Given this list of marker genes Mllt1, Pycard, Stk38, Ubash3b, Notch1, Limk1, Gfi1, Dbndd2, Hpn, Ajuba, Cav1, Ormdl3, Lrch1, Akt1, Hipk3, Serpina5, Rpl23, Cdkn2c, Gadd45g, Nup62, Ptpn1, Zfp36, Lyn, Crb2, Ppia, Ptprc, Rd3, Park7, Dab2ip, Serpinb8, Epm2a (epilepsy, progressive myoclonic epilepsy, type 2 gene alpha), Cep43, Rb1, Abl1, Prkch, Serpinb9e, Nprl2, Amot, Sirt1, Rasip1, Prkag2, Sort1, Nr2f2, Eng (NCBI Gene Id 99055), Spink2, Stfa2, Cstdc6, Tsc2, Ptpn22, Dgkh, Slc27a4, Ins2, Cstdc5, Cav3, Nf1, Prdx3, Atp5if1, Nfkb1, Ppp1r12a, Lrp6, Cblc, Sh3bp5 (NCBI Gene Id 24056), Dusp7, Vtn, Irs2, Csta2, Trib1, Serpinb6e, Rap1gds1, Dusp10, Ptpro, Chmp6, Mvp, Tfap4, Dnaja1, Ptprj, Serpinb9b, Errfi1, Casp3 (caspase 3), Macroh2a1, Thy1, Akt1s1, Gstp-ps, Cdk5rap3, Bag5, Rpl5, Rgs14, Coro1c, Gzma, Adgrv1, Cln3, Slc4a1, Nos1, Garem1, Palm, Gadd45a, Serpinb9g, Mtrr, Fabp4, Fbxo5, Sh3bp4, Cand1 (cullin associated and neddylation disassociated 1), Pkia, Apcs, Lats2, Spink1, Cst3, Angptl4, Serpinb9d, Cdkn1c, Plxnb3, Men1, Cstdc4, Apoc1, Rtraf, Gadd45b, Mkks, Tmem225, Timp2, Hspb1, Tmed2, Apoe, Slc8a3, Dnaja3 (DnaJ heat shock protein family (Hsp40) member A3), Rrp1b, Apba3, Ecm1, Serpinb6a, Wwtr1, Plec, Cyp27b1, Ppm1e (protein phosphatase 1E (PP2C domain containing)), Fetub, Mapk8ip1, Tmbim6, Pkig, Ins1, Terf1, Gba1, Zfyve28 (NCBI Gene Id 231125), Pkn1, Neil1, Stfa2l1, Spink5, Gprc5a, Ptx3 (pentraxin related gene), Taf7, Cast, Serpinb1b, Ptprb, Lats1, Slc8a1 (NCBI Gene Id 319418), Cstb, Cdk5rap1, Wnk1, Agt, Ptk6, Prkrip1, Cep85, Drd5, Midn, Prkar1a, Snca, Cstdc3, Ptpn2, Mt3, Chordc1, Pkib, Adarb1, Itgb1bp1 (NCBI Gene Id 16413), Gnaq, Gla, Adipoq, Sfrp1, Mad2l2, Serpinb9c, Gstp3, Rgs2, Bin1, Shb, Prdx5 (peroxiredoxin 5), Hexim2, Serpinb9, Arfgef1, Ggnbp2, Rps7, Ppm1f, Dusp22, Serpinb9f (NCBI Gene Id 80600), Psen1, Trib3, Acp4, Ubxn1, Arl2, Npm1 (NCBI Gene Id 18148), Ccar2, Camk2a, Il7, Chp1, Stfa1, Gapdhrt2, Serpinb6c, Dusp19, Fem1a, Stfa3, Inca1, Dtnbp1, Tsg101, Trim27, Nos3, Usp44, Lilrb4b, Pnkp, Cln8, Vps25, Cd300a, Spock1, Dtx3l, Dusp1, Hhex, Irak3, Banf1, Spock3, Nolc1, Spry1, Gckr, Prkcd, Uchl1, Cdkn1b, Gapdh, Spry4, Timp3, Atp2b4, Pla2r1, Terf2, Serpinb1a, Tmem132c, Gstp2, Serpine2, Bmp2, Csta1, Lrrk2, Angptl8, Tigar, Prkn, Nes, Nqo1, Inpp5k, Serpinb6b, Hmgcr, Hnrnpu, Grn, Reck, Epha1, Sfrp2, Tnfaip3, Angptl3, Pten, Ptprt, Qars1, Cst7, Paqr3, Zgpat, Apoc3, Tnf, Wfdc6a, Pdcd4, Fbxo7, Eif4a2, Cox11, Pparg, Nosip, Gstp1, Rdx, Spink6, Nppa, Ptprh, Timp1, Socs5, Lepr, Gapdh-ps15, Wars1, Gskip, Psen2, Serpine1 (NCBI Gene Id 231790), Serpinb9h, Apc, Lilrb4a (NCBI Gene Id 14728), Xrcc1, Bscl2, Dusp3, Sfrp5, Tinf2, Gsk3a, Serpinb13 (serine (or cysteine) peptidase inhibitor, clade B (ovalbumin), member 13), Heg1 (NCBI Gene Id 77446), Mapt, Dnajc3, Rcc2, Hyal2, Bbs4, Tmed10, Rpl11, Drd2, Myocd, Deptor, Usp17le, Gapdhrt, Hras, Gmip, Spry2, Tmbim1, Smyd3, Oxa1l, Ttc8, Uri1, Bag4, Nf2, Parp9, Mad2l1, Srcin1, Apoa2, Ifng, Plin5, Dffa, Aida, Eppin, Phpt1, Il1b, Ptpn6, Gpsm1, Akap5, Cdkn2a, Serpinb1c (serine (or cysteine) peptidase inhibitor, clade B, member 1c), Smad7, Blvra, Apoa1, Smpd1, Wnk4, Bag2, Spred1, Serpinb6d, Ceacam1, Cdkn1a, Adar, Wee2, Socs4, Csta3, Plk1, Setd7, Mstn, Kat2b, Prkca, here is a description of the gene set: Mouse Gene Set: GOBP_NEGATIVE_REGULATION_OF_CATALYTIC_ACTIVITY species: Mus musculus Any process that stops or reduces the activity of an enzyme.